Given this list of marker genes Kcna2, Apoe, Tent2, Nrxn3, Dbn1, Klhl17, Lrfn5, Kcnj8, Napb, Grm2, Mlf2 (myeloid leukemia factor 2), Atad1, Flot1, Slc12a5, Grm4, Dnm3, Myo9a, Dnm2, Adgrb3, Clta, Eps8, Gsg1l, Calb1, Dnajb1, Ap2s1 (adaptor-related protein complex 2, sigma 1 subunit), Kif3a, Ntng2, Celsr3, Ptprz1, Efnb1, Stau1, Sptbn1, Septin7, Clcn3, Cpt1c, Ghsr, P2ry2, Usp14 (NCBI Gene Id 98113), Ncs1, C1qc, Canx, Tiam1, Frmpd1, Tamalin, Tenm2, Syt10, Ptpro, Cbln2, Robo2, Nedd4, Cxadr, Ptprt, Adra1a, Nae1, Gria2, Hspa8, Gpc6, Sirt2, Adgrl2, Stxbp1, Slc16a7, Napa, Arhgef2, Sv2b, Myh10, Mgll, Gapdhrt2, Adgrl3, Cpeb1, Shroom4, Prrt1, Septin11, Gpm6a, Adgra1, Kcnab2, Gapdhrt, Psd2, Lrrtm1, Lrrtm4, Grid2ip, Ap3d1 (adaptor-related protein complex 3, delta 1 subunit), Dapk1, Itga8, Ppfia2, Cdh2, Grin1, Lrrc7, Vezt, Rab8a, Ppp3r1, Adra2c, Arhgap32, Eif4a3, Abl1, Hcn1, Arpc2, Cltc, Cdh10, Pak1, Rims2, Myo5b, Plxnc1, Apbb1, Numb, Sumo3, Limk1, Shisa9, Cbln4, Nlgn3 (NCBI Gene Id 245537, neuroligin 3), Cnih3, Fmnl2, Ncan, Scn8a, Podxl, Arfgef2, Adam22, Ror2, Grm1, Chmp2b, Map2k1, Stau2, Snap47, Rab4a, Hnrnpa3, Arpc5l, Cacng2, Creld1, Cntn1, Wdr1, Elmo1, Eef2k, Taok2, Kif3b, Gucy1b1, Tprg1l, Scn11a, Zdhhc5, Nsg1, Srgap3, Nsmf, Fzd4, Atg16l1, Sparc, Abi1, Erbb4, Lrfn3, Apba1, Grn, Hip1r, Cadps (NCBI Gene Id 27062), Zdhhc17, Lpar2, Ppp2r2a, Grip2, Prkci, Shisa7, Sptbn2, Shank1, Hnrnpk, Dnm1, Dlgap4, Lrfn4, Actb, Stx4a, Itsn1, Elavl4, Psen2 (presenilin 2), Tpd52, Tspoap1, Arhgap39, Acan, Unc13b, Pclo, Syn3, Elavl1, Actc1, C1ql1, Casr, Cdh1, Csmd2, Tfrc, Yes1, Adam10 (a disintegrin and metallopeptidase domain 10), Nr3c1, Rac1, Rhoa, Sez6l, Adam23, Slc1a6 (NCBI Gene Id 20513), Rps27rt, Ap2m1, Camk2b, Plg, Wasf3, Dicer1, Rhog, Epha7, Osbpl2, Rimbp2, Prkaca, Vamp1, Prrt2, Fyn (NCBI Gene Id 14360), Clstn2, Adrb2, Egln1, Sema3f, Tafa4, Slc6a7, Agap2 (NCBI Gene Id 216439), Mdm2, Elmod1, Camk2a, Chd4, Grik3, Sipa1l2, Plxna4 (plexin A4), Sh3gl2, Magi2, Sptan1, Syn2, Anp32e, Rbmx, Wnt7a, Ptk2, Drd4, Prkn, Pafah1b1, Grik4, Tsc2, Ncdn, Nrxn2, Cald1, Abtb3, Gabbr1, Ap2a1, Gucy1a1, Grik2, P2rx6, Slc17a5, Mpp2, Snap25, Ppp1r9b, Ago2, Ina, Slc2a3, Baiap2, Ppp3cc, Grm7, Plxna1, Adcy8, Lrrtm2, Cacna1h, Dlgap1, Tenm3, Rab11a, Hnrnpd, Pcdh17, Ppp1r9a, Tnc, Sarm1, Gria1, Dclk1, Gnao1, Crtac1, Arhgap33, Hnrnpm, Dynll2, Epha4, Cacng8, Lin7c, Sumo2, Sh3kbp1, Actr3, Adgrl1, Ncam1, Agrn, Itgb1, Map1b, Stk38, Ppp2r1a, Sh3gl3, Sharpin, Nlgn4l, Arf1, Fmr1, Erbin, C1qbp, Nrg2, Il1rap, Ptprs, Numbl, Ywhah, Homer3, Elfn1, Sparcl1 (SPARC-like 1), Neto1, Asic1, Vgf, Rgs9, Cacnb1, Camk1, Slc9a6, Igsf9, Sort1, Grk2, Arf4, Stx3, Prkar2a (protein kinase, cAMP dependent regulatory, type II alpha), Eif4a3l2, Nbea, Rabep1, Tanc1, Cfl1, Nudt3, Scn2a (sodium channel, voltage-gated, type II, alpha), Lama5 (NCBI Gene Id 99115), Grk3, Caskin1, Neto2, Gabbr2, Ddx3x, Sorcs3, Cnn3, Drd2, Strn4, C9orf72, P2ry1, Plxnb1, Nrp1, Ano1, Hip1, Adgrb2, Cadps2 (Ca2+-dependent activator protein for secretion 2), Abhd17c, Dbnl, Cpsf2, Cabp1, Cyth2, Nrgn, Ctnnd1, Slc1a7, Vldlr (NCBI Gene Id 22359), Slc6a17, Dgki, Bsn, Ppp1r1b, Abhd17a (NCBI Gene Id 76403), Rims3, Thy1, Kcnj11, Kcnj4, Gabrr1, Rheb, Eef1d, Sema4c, Adcy1, Psen1, Brinp1 (NCBI Gene Id 56710), C1qa, Ryk, Itgb5, Cplx2, Calr (calreticulin), Plekha5, Grm8, Rapgef4, Ube3a, Cblb, Grin2b, Porcn, Lrrc4, Fbxo45, Actn2, Ablim3, Eps15, Nrg3, Cpeb2, Ube2n, Pja2, Kif21b, Braf, Vwc2 (von Willebrand factor C domain containing 2), Itga5, Prr7, Pcdh10, Syt7, Ube3b, Tacc3, Sh3glb2, Cdh11, Caprin1, Lrrc4b, P2ry4, Vps26b, Arhgef15, Lingo1, Ppfia4, Vasp, Cdk5, Lrrk2, Ntrk2, Doc2b, Btbd9, Usp46, Nr3c2, Gria4, Rasgrf2, Slc4a8, Grin3a, Actbl2, Sqstm1, Arhgap22, Mapk3, Cript, Rgs14, Hnrnpa2b1, Arc, Drd5, Gipc1, Slc1a2, Dock10, Dact1, Stat3, Grik1, Kif2c, Phb2, Plcb4, Rab5a, Fzd3, Gapdh, P2rx2, Fus, Grm5, Pi4k2a, Slc6a8, Bcan, Pik3c3, Git1, Dock1, Unc13a, Shank3, Hpca, Dock4, Pip5k1c, Nedd8, Lats1 (large tumor suppressor), Wasl, Srpx2, Nos1ap, Ap2b1, Sigmar1, Lrp1, Dgkq, Dixdc1, Add2, Disc1, Nrg1, Lpar1, Syt4, Vps18, Mapk14, Rnf19a, Ap3m2, Drp2, Gabrd, Synpo, Pak2, Slitrk4, Dcx, Syndig1, Il1rapl1, Rap1a, Cadm1, Rps6kb1, Efnb2, Ptpn1, Psd3, C1qb, Tnr, Ano2, Cspg5 (NCBI Gene Id 29873), Mecp2, Apc, Dgkb, Dpysl5, Cap2, Olfm2, Ppp1cc, Igsf11, Snx27, Dip2a, Efr3a, Dlg4, Stk38l, Srgap2, Rgs7bp, Slitrk5, Nrxn1, Adgrb1, Fzd5, Eef2, Prmt8, Grm3, Cttnbp2, Lrp8, Plxnd1, Sipa1l3, Mark1, Nptn, Rnf10, Pacsin1, Wnt3a, Ngef, Iqsec1 (NCBI Gene Id 79407), Kpna2, Homer1, Farp1, Rgs7, Coro1a, Dlg1, Grik5, Mtor, Begain, Dag1, Cnksr2, Sv2a (NCBI Gene Id 99706), Hras (Harvey rat sarcoma virus oncogene), Adra2a, Kcnd2, Synj1, Ghrl, Cacna1a, Htr2a, Vcp, Abi2, Amph, Pias1, Nckipsd, Tmem108, Amot, Tmem240, Eif4e (NCBI Gene Id 668879), Mark2, Plcxd3, Kalrn, Shisa6, Crhr1, Cntnap1, Grid1, Adora2b, Pum2, Fam81a, Ngdn, Cap1, Sema4b, Nsg2, Gabrb2, Cdc42, Eea1, Tenm4, Scrib, Atp2b4, Usp8, Chrm4, Caly, Prune2, Prickle2, Adora2a, Ywhaz, Phb1, Notch1, Slitrk1, Cdh6, Cacng7, Rab17, Abhd17b, Ppp2r1b, Lzts3, Sema4f, Gsk3b, Atp2b3, Rpl22, Cnnm2, Sema3a, Ppp1ca, Pin1rt1, Grin2d, Rtn4, Ntn1, Htr4, Nlgn1 (neuroligin 1), Ywhae, Prss12, Jak2, Vhl, Igf1r, Syt6, Mpdz, Prkcz, Traf6, Dvl3, Map1lc3a, Fbxo2, Chrm1, Cttn, Rnf220, Rab7, Efnb3, Ophn1, Drosha, Appl1, Dvl1, Ube2i, Lzts1, Arhgap44 (NCBI Gene Id 216831), Cnr1, Fabp5, Lgi1 (leucine-rich repeat LGI family, member 1), Kcna3, Lyn, Carmil3, Chrm3, Plcg1, Cacng3 (NCBI Gene Id 54376, calcium channel, voltage-dependent, gamma subunit 3), Cdkl5, Ehd1, Itga3, Itgb3, Rac3 (Rac family small GTPase 3), Nos1, Rims4, Cpne4, Mib1, Fgf22, Ptprd, Camkv, Slc17a8, Mdga2, Fxyd6, Sos1, Eif4a3l1, Tnik, Aurka, Clstn1, Lrrc4c, Dstn, Rims1, Ephb1, Scn10a (NCBI Gene Id 208230), Pak3, Dlg5, Mal2, Lrrtm3, Pcdh8, Kcnma1, Inpp4a, Rpsa, Cul3, Myo6 (myosin VI), Flrt2, Daam1, Htr1d, Kcnn2, Trio, Stx1a, Nptx2, Actn1, Atp2b1, Cacng4, Pfn2, Nrn1 (neuritin 1), Pfn1 (profilin 1), Comt, Phf24, Ptk2b, Egfr, Vamp2, Dlgap2, Drd3, Trim47, Gripap1, Htr3a, Tanc2, Pick1, Src, Zdhhc8, Akap9, Ctbp2 (NCBI Gene Id 52060), Ctnnb1, Lck, Pura, Pin1, Rtn4r, Itgb4, Igf1, Abhd6, Anks1b, Gabrg2, Nptxr (neuronal pentraxin receptor), Abr, Nxph1, Trim3, Flna, Gria3, Neo1, Prkce, Kcna1, Cplx1, Ntrk3, Vangl2, C1ql3, Fzd9, Nf1 (neurofibromin 1), Cnih2, Bin1, Als2, Dgcr8, Cacng5, Cdh8, Kcna4, Dab1, Rps27, Slc30a3, Abl2, S1pr2, Itpka, Nedd4l, Marcks, Akap5, Cacna2d1, Casp3, Clstn3, Rmdn3, Homer2, Chrm2, Pacsin2, Syngap1, Sumo1, Cbln1, Srcin1, Syt1, Plat, Grip1, Ntng1, Cacnb4, Coro1b, Nrcam, Bdnf, Ephb2, Cacna1b, Chmp4b, Ogt, Neurl1a, Wnt5a, Eif4ebp1, Crtc1, Grin2a, Ppm1h, Arf6 (ADP-ribosylation factor 6), Flrt3, Bcr, Cpeb3, Rela (NCBI Gene Id 19697), Doc2a, Grin2c, Praf2, Grid2, Prkar1b, Prkar1a, Pias3, Syt17, Elavl2, Kifap3, Nptx1, Sh3gl1, Cntnap2, Cdh9, Akt1, Asap1, Arrb2, Parn, Camk4 (calcium/calmodulin-dependent protein kinase IV), Pgrmc2, L1cam, Cnrip1, Filip1 (filamin A interacting protein 1), Myo5a, Fam107a, Arpc1a, Dgkz, C1ql2 (complement component 1, q subcomponent-like 2), Snap23, Atg5, Rnf216, Ppp3ca, Dtnbp1, Ctbp1 (NCBI Gene Id 51972), Erc1, Pde10a, Plppr4, Abi3, Zdhhc2, Pdxp, Cc2d1a, Rap1b, Dlg3, Fgfr1, Ppfia3, Mapk10, Nrp2, Frmpd4, Ctnnd2, Atp2b2, Kcnc4, Dlg2, Ube2m, Prickle1, P2rx1, Shank2, Olfm1, Slitrk2, Sptb, Hnrnpab, Rtn3, Kcnj2, Clasp2, Prkar2b, Kpna1, Plcb1, Gpc4, Mob4, Atp8a1, Dgke, Cacna1c, Kcnc3, Htt, Npy1r, Fxr2, Erc2, Cd47, Iqsec2, Fbxl20, Dlgap3, Icam5, Lingo2, Fxr1, Vps35, Sipa1l1, Sacm1l, Flot2, Ppp3cb, Map2, Drd1, Rock2, Snx6, Il1rapl2, Faah, here is a description of the gene set: A synapse that uses glutamate as a neurotransmitter. species: Mus musculus Mouse Gene Set: GOCC_GLUTAMATERGIC_SYNAPSE